The following is a description of a gene set: species: Homo sapiens part of: Sensory processing of sound Reactome Pathway: Sensory processing of sound by inner hair cells of the cochlea Inner hair cells (IHCs) of the cochlea transduce sound waves into an ionic (mainly potassium) current that leads to exocytosis of glutamate from the IHC and activation of postsynaptic type I afferent fibers of the radial ganglion. IHCs have stereocilia on their apical surface that are arranged in rows of increasing height, a "staircase" arrangement. Stereocilia of different rows are connected by a tip link comprising a CDH23 dimer on the taller stereocilium bound to a PCDH15 dimer on the shorter stereocilium. PCDH15 interacts with LHFPL5, an auxiliary subunit of the mechanoelectrical transduction channel (MET channel, also called the mechanotransduction channel), which contains at least TMC1 (adults) or TMC2 (newborns), TMIE, and the auxiliary subunits LHFPL5 and CIB2.<br>Deflection of the stereocilia by sound waves creates tension on the tip link that increases the open probability of the MET channel, which then transports calcium and potassium ions from the scala media into the IHC, depolarizing the IHC. The potassium channel KCNQ4 located in the neck region of the cell may also participate in depolarization. The depolarization of the IHC opens voltage-gated Cav1.3 channels (CACNA1D:CACA2D2:CACNB2) located in stripes near ribbon synapses on the basolateral surface of the IHC. The resulting localized influx of calcium ions activates exocytosis of glutamate into the synapse by an interaction between calcium and Otoferlin (OTOF) on glutamate-loaded vesicles in the IHC.<br>Ribbon synapses are characterized by a multiprotein complex, the ribbon, that contains at least BASSOON, RIBEYE (an isoform of CTBP2), and PICCOLINO (a small isoform of PICCOLO) and appears to act to transiently tether vesicles near the synapse and thereby increase the pool of readily releasable vesicles.<br>ATP2B1 calcium channels, ATP2B2 calcium channels, KCNMA1:KCNMB1:LRRC52 potassium channels, and basolateral KCNQ4 potassium channels transport cations out of the IHC and thereby act to repolarize the cell and limit the duration of the synaptic potentials., and this is the list of marker genes: ACTB, CABP1, CIB2, LRRC52, MYO1C, RIPOR2, MYO3B, CASK, SLC17A8, TRIOBP, DNAJC5, EPB41L3, BSN, PJVK, CABP2, CLIC5, SPTBN1, CAPZB, RDX, MSN, EZR, USH1G, SNAP25 (synaptosome associated protein 25), VAMP2, CACNA1D, USH1C, PLS1, EPS8, MYO3A, PCDH15, SPTAN1, ATP2B2, ESPN, MYH9, WHRN, EPB41L1, KCNQ4, ESPNL (NCBI Gene Id 339768), MYO15A, TMC2, TPRN, EPS8L2 (NCBI Gene Id 64787), CAPZA2, PCLO, KCNMA1, CAPZA1, FSCN2, ATP2B1 (ATPase plasma membrane Ca2+ transporting 1), XIRP2, TMC1, RAB3A, OTOF, GRXCR2 (glutaredoxin and cysteine rich domain containing 2), CACNA2D2, STRC, TWF2, STX1A, MYO7A, ACTG1, LHFPL5, KCNMB1, TMIE, SYP, TWF1, CDH23, SYN1, CACNB2, CTBP2, GRXCR1